The following is a description of a gene set: The chemical reactions and pathways resulting in the breakdown of coenzyme A, 3'-phosphoadenosine-(5')diphospho(4')pantatheine, an acyl carrier in many acylation and acyl-transfer reactions in which the intermediate is a thiol ester. Mouse Gene Set: GOBP_COENZYME_A_CATABOLIC_PROCESS studied in species Mus musculus, and this is the list of marker genes: Alpi, Enpp1, Nudt8, Vnn1, Nudt7, Pank4, Nudt19